Given this list of marker genes ALDH6A1, TMEM31, IL1R2, SERPINI1, PCMTD1, CRIPTO, ITGB8, ANXA2, TMOD4, DENND1C, CD96, SAMTOR, SPOCK2, P2RX7, KCNA3, RGL2, CARNS1, EPSTI1, CHST10, HEXB, SCG5, ZNF292, MAP3K3, RASGRP2 (RAS guanyl releasing protein 2), CSGALNACT1, CCNG2 (NCBI Gene Id 901), CDC42SE2, ITM2C, HCST, NMB, CTSE, AXIN2, CHDH (choline dehydrogenase), XAF1, SDC4, L1CAM, PRKX, DHX58, DZIP1 (NCBI Gene Id 22873), RAPGEF5, PGLYRP1, CYTH1, KIAA0040, DDX60, CYRIA, RAPGEF2, STK10, BLVRB, ZCCHC18, FAM117A, ARHGAP4, ABCB1, WDR26, S100A6, RIPOR2, GABRR2, SLC14A1, TMEM154, ULK2 (NCBI Gene Id 9706), PHLPP1, C3orf70, GPR183, HMG20A, TP53I11, CREBBP, PGLYRP2, MATK, PTPN13, MAN1A1, TECPR1, DTX1, CYBB, H2BC3, KBTBD11, SMPDL3A, ZDHHC15, SDCBP2, DBNDD2, KLRG1, RAP1GAP2, PTPRE, ASH1L, IFIT1, HAPSTR1, SLAMF6, ZFP36L1, RPRD2, NRP1, FCHSD1, GLRX, SLC35B3, PHF1, ACAP1, VRK3, TTC28, IL1RAP, DMTF1 (cyclin D binding myb like transcription factor 1), CLK1, DPP4, CYP4F3, FAH, NOD1, HAL, CREB1, PRKAB1, CDC42EP3 (CDC42 effector protein 3), ARHGEF18, SPACA1, IL1RL1, HVCN1, ARHGAP18, GM2A, PRR14, GLCCI1, ZMYND11, ARHGAP20, AMPD3, RAPGEF6, SLC9A9, CRIM1, ADD1, SMAP1, ECM1, MAP2K6, CD8B, MYLIP, IFT80, HSDL1, OS9, GSDMD, MEX3B, BTLA, C5orf34, OSGIN1, ABCA7 (ATP binding cassette subfamily A member 7), CCNL2, BICRA (BRD4 interacting chromatin remodeling complex associated protein), LAMC1, UTRN, EVA1B, ASAP1, EPHB6, ARHGEF10, BAZ2B, PLEKHG2, RSBN1, SMC6, SYTL2, TUT4, EVI2B, RASGRF2, CD84, RGS14, PITPNM1, LGMN, TMEM63A, GMFG, NRIP1, CCL5, PNPLA7, AMPD1, PAQR7, TPCN1, CD7, SAPCD1, SWAP70, MYO1F, MXRA8, NBEAL1, PGAP1, RIGI, AKNA, HIP1R, GPLD1, RAB37, SH3BGRL2, PLCB4, DAXX, GUCY1A1, S100A4, RFX1, KMT2E, IRF7, ADGRE5, BICRAL, SORL1, TSPAN13, SYNE1, PTPN18, CD1D, CCR9, CD200R1L, SRPK2, ARID4B (AT-rich interaction domain 4B), ATP10D (NCBI Gene Id 57205), UBAC2, KDM7A, GIMAP4, ARRB1, ARHGAP9, here is a description of the gene set: Human Gene Set: GSE16450_IMMATURE_VS_MATURE_NEURON_CELL_LINE_12H_IFNA_STIM_UP Human neuronal differentiation alters responsiveness to innate immune stimuli and virus infections. We used microarrays to examine the transcriptional responses of the human BE(2)-C neuroblastoma cell line to retinoic acid-induced differentiation and type I IFN stimulation. from publication Peltier DC, Simms A, Farmer JR, Miller DJ (PMID 20483728) studied in species Homo sapiens Genes up-regulated in neuron cell line treated with interferon alpha for 12h: immature versus mature.